The following is a description of a gene set: The presence of cell death (necrosis) affecting the liver. Human Gene Set: HP_HEPATIC_NECROSIS Hepatic necrosis studied in species Homo sapiens, and this is the list of marker genes: TERC, NHLRC2, ETFA, DGUOK, HADH, ACADVL, TERT, MET, SDHD, ETFDH, ETFB, MPV17, CTNNB1, TINF2